Given this list of marker genes ENSG00000288063, SLC25A20, TOPAZ1, PRSS44P, PTPN23, FLT1P1, SELENOK, GLYCTK-AS1, RRP9, UCN2, NME6, CCDC12, CCR9, ZDHHC3, LZTFL1, IQCF6, IQCF2, SNRPFP4, UBA7, AKTIPP1, STIMATE-MUSTN1, CDCP1, GPX1, MST1R, SEMA3B-AS1, MIR4271, CCR3, ENSG00000223343, CDC25A (cell division cycle 25A), HIGD2AP2, SPCS1, BSN (bassoon presynaptic cytomatrix protein), KIF9 (kinesin family member 9), TUSC2, KLHDC8B, FAM240A, UQCRC2P1, HYAL2, GPR62, UQCC5, LTF, PPIAP69, LRRC2-AS1, STAB1, ALDOAP1, NEK4, MIRLET7G, ZMYND10-AS1 (ZMYND10 antisense RNA 1), ITIH3, RPL29, PRSS43P, SNORD63, RN7SL664P, BSN-DT (BSN divergent transcript), LINC01988, LINC02009, TREX1, ABHD14A-ACY1, RNU6ATAC29P, MIR138-1, C3orf86P, RHOA-IT1, BSN-AS1, WDR82, BLVRBP1, C3orf18, LIMD1-AS1, BAP1 (NCBI Gene Id 8314), MIR564, CELSR3, SEMA3F-AS1, WDR6, SNORD13P3 (small nucleolar RNA, C/D box 13 pseudogene 3), RPL12P44, CHDH, TMA7, NBEAL2, MIR6823, IFRD2, CCR2, NICN1, ZMYND10, HYAL3, ABHD14A, AK3P7, CCRL2, PRKAR2A, SMARCC1, RN7SL321P, LSMEM2, MIR425, GNL3 (G protein nucleolar 3), TMEM89, MIR711, RPS25P4, CLEC3B, LARS2-AS1, KIF9-AS1, CSPG5, SNORD69, PTH1R, GNAI2, TMEM42, ELP6, MIR4793, PLXNB1, PFKFB4, ANO10, RNU7-128P, CCR1, CABYRP1, AMT, ZNF35, RN7SL182P, DNAH1, TEX264, FBXW12, DCP1A, HYAL1, FYCO1, SCAP (NCBI Gene Id 22937), CDHR4, RHOA, SLC6A20, PRSS50, ZNF660, MIR191, PPM1M, NDUFB1P1, ZNF445, TRAIP, NRBF2P2 (nuclear receptor binding factor 2 pseudogene 2), MRPS18AP1, PARP3, IL17RB, KIAA1143, ACTL11P, CCR5AS, ITIH4-AS1, ZNF589, DUSP7, RAD54L2, TWF2-DT, CCDC51, MPRIPP1, RNA5SP130, USP4, IP6K2, RN7SL870P (NCBI Gene Id 106481155), RNU6ATAC16P, QARS1, IP6K1, RBM5-AS1, MYL3, SOCS5P3, TLR9, MIR4443, XCR1, LINC02585, LAMB2, INKA1, COL7A1, RNA5SP131 (NCBI Gene Id 100873400), CIMIP7, RNA5SP132, PHF5AP3, MRPL57P3, DALRD3, SHISA5, NDUFAF3, RN7SL217P, POC1A, TKT, PRSS45P, NRADDP, IHO1 (NCBI Gene Id 339834), CACNA2D3, FCF1P2, KLHL18, PBRM1, C3orf62, MIR6890, SNORD19C, RASSF1, ABHD5, CAMKV, PRKAR2A-AS1, BOLA2P2, MIR135A1, ARIH2OS, RNU5B-3P, DHX30, SPMIP3P1, SLC26A6, MIR6824, SACM1L, TNNC1, RPL17P16, CCR5, MIR2115, CACNA1D, CCDC71 (coiled-coil domain containing 71), LARS2, RBM5, APEH, MIR8064, GLT8D1, MUSTN1, NISCH, MON1A, IQCF4P, RPS27P30, LRRC2, NAA80, TMIE, MIR5193, SPINK8, GNAT1, MIR5787, CISH, ZNF502, VPS26BP1, CRIPTO, AMIGO3, PTPN23-DT, DAG1, TMEM115, MIR6872, RTP3, NCKIPSD, SEMA3B, CACNA2D2, RBM15B, SNORD19B, RN7SL145P (NCBI Gene Id 106481753, RNA, 7SL, cytoplasmic 145, pseudogene), ENSG00000212608, RPS24P8, EXOSC7, USP19, TMEM158, TWF2 (NCBI Gene Id 11344), ENSG00000202268, PRSS46P, LIMD1, ALS2CL, TCAIM, ALAS1 (5'-aminolevulinate synthase 1), ACTR8, COX6CP14, PCBP4, NPRL2, MIR1226, TCTA, SETD2, CAMP, MST1, IQCF5-AS1, MIR4787, GMPPB, KIF15, ZNF852, SEMA3G, RNU6-856P, IMPDH2, SEMA3F, EI24P3, IQCF3, ZKSCAN7, ITIH4, ST13P14, ITIH1, LINC02019, RNU6-367P, CXCR6, GRM2, ACY1, QRICH1, ABHD14B (abhydrolase domain containing 14B), ZNF197, SDHDP4, PRKCD, GCSHP6, SFMBT1, GLYCTK, MAPKAPK3, PPP2R5CP, DOCK3, ARIH2, SNORD19, PRSS42P, DCAF1, LAMB2P1, MAP4, RNF123, RBM6, HEMK1, CYB561D2, RN7SL504P, IQCF5, MANF, ZKSCAN7-AS1, ATRIP (ATR interacting protein), UQCRC1, TGM4, RFT1, ZNF652P1, SLC38A3, ENSG00000271858, NT5DC2, STIMATE, P4HTM, PHF7, IQCF1, SNORD38C, ZNF501, SERBP1P3, RASSF1-AS1, here is a description of the gene set: Human Gene Set: chr3p21 species: Homo sapiens